The following is a description of a gene set: studied in species Homo sapiens Any process that activates or increases the frequency, rate or extent of axon extension. Human Gene Set: GOBP_POSITIVE_REGULATION_OF_AXON_EXTENSION, and this is the list of marker genes: DISC1, SRF, BMPR2, ISLR2, MAP3K13, ZFYVE27, POU4F2, NGF, FN1, ADNP, ANAPC2, GOLGA4, PAK1, SMURF1, VEGFA, MAPT, TRPC5, TWF2, SEMA7A, ADCY10, NTN1, CDKL5, MEGF8, NTRK3, RUFY3, MACF1, SHTN1, NRP1, LIMK1, PAFAH1B1, TNFRSF12A, SEMA5A, GDI1, TRPV2, L1CAM, CXCL12, CDH4, MAP1B, DSCAM